The following is a description of a gene set: The chemical reactions and pathways resulting in the formation of a pyrimidine-containing compound, i.e. any compound that contains pyrimidine or a formal derivative thereof. studied in species Homo sapiens Human Gene Set: GOBP_PYRIMIDINE_CONTAINING_COMPOUND_BIOSYNTHETIC_PROCESS, and this is the list of marker genes: UMPS, NME6, TK2, UCK1, DCK, NME2, DHFR2, SLC25A19, TYMS, CDA, NME3, UCKL1, SHMT1, UPP1, NME7, UCK2, DUT (NCBI Gene Id 1854), CMPK1, DHODH, UPP2, TPK1, CTPS1, DTYMK, NME5, AK9 (adenylate kinase 9), TBPL1, NME1, TK1, NME2P1, DCTD, CTPS2, MTOR, SLC19A2, CMPK2, UPRT, SLC19A3, NME4, PRPS1, AK5, CPS1, CAD, THTPA, SLC4A7, NME9